Given this list of marker genes Taf11, Trim11, Rest, Brd4, Inpp5k, Ccl5, Trim8, Trim21, Ep300, Hmga2, Ccnt2, Ifitm3, Ubp1, Hexim1, Gtf2b (general transcription factor IIB), Trim13 (tripartite motif-containing 13), Lef1, Pou2f3 (POU domain, class 2, transcription factor 3), Trim31, Larp7-ps (NCBI Gene Id 68280), Trim27, Trim14, Trim32, Rsf1, Tarbp2, Hpn, Smarcb1, Sp1, Chd1, Rrp1b, Mon1b, Zfp36, Ctdp1, Ccl3, Mdfic (NCBI Gene Id 16543), Usf1, Mid2, Tardbp, Ccnt1, Cdk9 (NCBI Gene Id 12574), Sp100, Smarca4, Ifitm7, Notch1, Jun (jun proto-oncogene), Nucks1, Dhx9, Trim62, Larp7, Snw1, Pfn1 (NCBI Gene Id 18643), Hdac1, Map3k1, Zfp639, Tfap4, here is a description of the gene set: studied in species Mus musculus The process by which a viral genome, or part of a viral genome, is transcribed within the host cell. Mouse Gene Set: GOBP_VIRAL_TRANSCRIPTION